Given this list of marker genes Ago1, Ago2, Tsn, Ago4, Tsnax, Prkra, Ago3, Tarbp2, here is a description of the gene set: Small interfering RNA (siRNA) biogenesis species: Mus musculus Mouse Gene Set: REACTOME_SMALL_INTERFERING_RNA_SIRNA_BIOGENESIS